Given this list of marker genes Dhh, Shh, Ihh, Gpc5, Scube2, Notum, Disp2, here is a description of the gene set: studied in species Mus musculus Release of Hh-Np from the secreting cell Mouse Gene Set: REACTOME_RELEASE_OF_HH_NP_FROM_THE_SECRETING_CELL